The following is a description of a gene set: Primary focal segmental glomerulosclerosis (FSGS) species: Mus musculus Mouse Gene Set: WP_PRIMARY_FOCAL_SEGMENTAL_GLOMERULOSCLEROSIS_FSGS, and this is the list of marker genes: Dag1, Mme, Cdkn1c, Itga3, Cdkn1a, Cd151, Tgfb1, Nck1, Inf2, Fyn, Itgb4, Myo1e, Itgb1, Lamb2 (laminin, beta 2), Irf6, Plaur, Ywhaq, Ilk, Lrp6, Scarb2, Ctnnb1, Smarcal1, Col4a3, Lama5, Nphs1, Lims1, Cd80, Cldn1, Dnm1, Tlr4, Plce1, Vim (vimentin), Pax2 (NCBI Gene Id 207129), Ptk2, Podxl, Synpo, Vtn, Nphs2, Trpc6, Wt1, Akt1, Actn4, Mki67, Krt8, Agrn, Utrn, Myh9, Cdh2, Cr1l, Col4a4, Fat1, Ctsl, Camk2b, Lmx1b, Vcl, Itgb3, Tln1, Jag1, Lrp5, Pcna, Ptpro, Plcg1 (NCBI Gene Id 99130), Itgav, Cdkn1b (cyclin dependent kinase inhibitor 1B), Kirrel2, Parva, Cd2ap, Dkk1, Notch1, Col4a5, Kirrel3